The following is a description of a gene set: Abnormal apoptosis by peripheral blood T cells in an in vitro culture, compared to a healthy control sample. May be either spontaneous, induced by UV, X-ray, FasL or other agens. Commonly measured by surface expression of phosphatidyl serine labelled by Annexin V, but other methods such as staning of cleaved Caspases may be used by different laboratories. Abnormal T cell apoptosis Human Gene Set: HP_ABNORMAL_T_CELL_APOPTOSIS studied in species Homo sapiens, and this is the list of marker genes: CASP10, FASLG, CASP8, KRAS, FAS, NRAS